Given this list of marker genes SUMO1, PIAS2, PIAS1, XPO1, RANBP2, HDAC1, RANGAP1, MDM2, RAN, HDAC4, UBE2I, here is a description of the gene set: Sumoylation by RanBP2 regulates transcriptional repression from publication Schaefer CF, Anthony K, Krupa S, Buchoff J, Day M, Hannay T, Buetow KH (PMID 18832364) species: Homo sapiens Human Gene Set: PID_RANBP2_PATHWAY